Given this list of marker genes STUM, RUNX1T1, NME6, RAD51B, RAB5C, PRF1, FCN1, ADGRG6, TMEM196 (NCBI Gene Id 256130, transmembrane protein 196), ARID5B, ATP6V1B1, VEPH1, SPOCK3, CERS6, EIF3J, LRAT, PCDH17 (protocadherin 17), STXBP5, APLN (apelin), SH3BP1, SPATA2L, CBLB, VWF, ASB7, USP8, MYOF, KIAA1549L, AQP6, RPL28, OLFML1, CLDN10, TNRC6A, LOXL3, ETV5, EBF3, SYCE1, FAF2, CINP, here is a description of the gene set: studied in species Homo sapiens Genes predicted to be targets of miRBase v22 microRNA hsa-miR-4265 in miRDB v6.0 with MirTarget v4 prediction scores > 80 (high confidence targets). from publication Chen Y, Wang X (PMID 31504780) Human Gene Set: MIR4265